Given this list of marker genes WNT7A, TBXT, CCL2, NODAL, HAAO, VANGL1, FANCB, FUCA1, ROR2, FANCL, PTH1R, FUZ, ZIC3, VANGL2 (NCBI Gene Id 57216), MNX1, RPS19, TP63, TRIP11, POC1A, here is a description of the gene set: Aplasia or developmental hypoplasia of the sacral bone. Human Gene Set: HP_APLASIA_HYPOPLASIA_OF_THE_SACRUM Aplasia/Hypoplasia of the sacrum studied in species Homo sapiens